Given this list of marker genes NBN, RBBP8, BRCA1, BARD1, RAD50, MRE11, here is a description of the gene set: species: Homo sapiens Human Gene Set: GOCC_BRCA1_C_COMPLEX A protein complex that contains the BRCA1-BARD1 heterodimer, CtIP and Mre11/Rad50/NBS1 (M/R/N) complex, and binds to DNA at DNA damage sites. BRCA1-C binding ta damaged DNA is required for DNA damage-induced Chk1 phosphorylation and the G2/M transition checkpoint.